Given this list of marker genes Gps2, Ywhae, Cd300a, Pdpk1, Lrrc14, Irf4, Pik3ap1, Trim30a, Cd300lf, Otud4, Cactin, Gpr108, Tyro3, Nfkbil1, Rnf115, Irak3, Smpdl3b, Arrb2 (NCBI Gene Id 216869), Ptgs2os, Nlrp6, Lgr4, Sarm1, here is a description of the gene set: Mouse Gene Set: GOBP_NEGATIVE_REGULATION_OF_TOLL_LIKE_RECEPTOR_SIGNALING_PATHWAY Any process that stops, prevents, or reduces the frequency, rate, or extent of toll-like receptor signaling pathway. studied in species Mus musculus